The following is a description of a gene set: The expansion of an immature T cell population by cell division. species: Homo sapiens Human Gene Set: GOBP_IMMATURE_T_CELL_PROLIFERATION, and this is the list of marker genes: IL1B, BMP4, IHH, TMEM131L, SHH (sonic hedgehog signaling molecule), IL1A, CLEC4G, GNRH1, TNFRSF9, CDKN2A, ERBB2, FOXP3, RIPK2, WNT4, BMI1